Given this list of marker genes Or4c10b, Or6c3 (NCBI Gene Id 258544), Or5d3, Or52z1 (NCBI Gene Id 259121), Or2y8, Or7d10, Pip, Or4k38 (NCBI Gene Id 259136), Or2z2, Or8g23, Or2d2b, Or1j14, Calhm1, Or1e19, Or4a79, Or11g25, Or52m1, Or10ak16, Or13c7, Asic2, Or2b28, Or5bw2, Or3a4, Or2d2, Or10p1, Or6d14, Or52n2b, Or52z13, Or5p80, Or5w18, Or5p52, Or12d16-ps1, Or5p56, Or10g6, Or5b98, Or2b2b, Or6c70, Or4a2, Or6b2, Or9q1, Or7e168, Or2y14, Or5aq6, Or5b121, Or2ak7, Or51e1, Olfr363-ps, Or1e1, Or2g1, Or8b40, Or1e30, Or12e10, Or2w25, Or10ag52 (olfactory receptor family 10 subfamily AG member 52), Or5ak25, Or13e8, Or5b120, Or6c1b, Or5w20, Or1l4, Or6z6, Or6c66b, Or5p64, Tas2r108, Or4k40 (NCBI Gene Id 277562), Or5aq1b, Or8b12i, Or4b1, Or10al6, Or5p55, Or5e1, Or6d12, Or8b56, Or10q1b, Or2w1, Or5b24, Or2c1, Or9r7, Or8b49, Or52b3, Or8k27, Or1e26 (NCBI Gene Id 259025), Or2m12, Or10g9, Or2w1b, Or51ag1, Or2l13b, Or6c211, Tas1r2, Or10h1, Or8c20, Or4c1 (olfactory receptor family 4 subfamily C member 1), Or52n2c, Tas2r136, Or1e33, Or1j1, Or2n1, Or7e169, Or5d38, Or7a37, Or5ak24, Or2w6, Or10d5, Or5v1b, Or1f19, Or8g22, Or9a4, Or6c65, Or1ad6, Or6c219, Or1e1c, Or4a71, Or5c1, Tas2r144 (taste receptor, type 2, member 144), Or52ab2, Or10p22, Or5b122, Or2r3, Or7c19, Or8g2, Or2v2, Or2a12, Or12k5, Or6b2b (NCBI Gene Id 258228), Or4c111, Or2y1d, Or51l4, Rtp1, Or4k49, Or8b35, Or9k2, Or5ar1, Or6c210, Or7a42, Or11g7, Or51b4, Or7a40, Or10ag58 (olfactory receptor family 10 subfamily AG member 58), Or4a72, Or51f1, Or10ad1b (olfactory receptor family 10 subfamily AD member 1B), Or52d1, Or14c45, Or5au1, Tas2r140, Or2y3, Or52ad1, Or10x4, Or10ag54, Or10q3, Or5ac25, Or51ah3, Tas2r110, Or5p76, Slc6a3, P2rx3, Or2bd2, Or2aj6, Or5g23, Or5k15, Or4k5, Or8g2b, Or4c118, Or9a2, Or56b2j, Or10h28, Or52n4b, Or8j3c, Or8b1b, Or5g26, Or5d36, Or10al7, Or56b6, Or10u3, Or8b57, Or51b17, Or6k14 (NCBI Gene Id 259162), Or4e2, Or4c102, Tas2r131 (taste receptor, type 2, member 131), Or52ae9, Or2n1e, Or6c33, Or14a258, Or1j15, Or1af1, Or7g18, Or10d1b, Or5ac24, Or8d23, Or8b44 (NCBI Gene Id 258801), Or4c121, Or6c202, Gjb4, Or4a74, Or14c40, Or12k7, Or52n2, Or8b8, Obp1b, Or2d3c, Or5p79, Or5as1, Or6c205, Or8b50, Azgp1, Or2ad1, Or2w4, Or2ag2, Or4c11b, Or2t47, Rgs21, Or8b36, Or10v1, Or52d3, Or10g1, Or4x15, Or4c127, Or51b6, Or4c113, Or4k52, Or4c120, Or5ac22, Or4f14b, B3gnt2, Or2aj4 (olfactory receptor family 2 subfamily AJ member 4), Or5b95, Or10g3b, Or2at4, Or12e8, Or52a5b, Or51r1, Obp1a, Bpifb9a, Or10aa3, Or1o11, Or1o4, Or4x13, Or5k1b, Or8g24, Or5bb10, Or2a14, Or2y1e (NCBI Gene Id 258460), Trpv1, Or13a25, Or4n5, Or5p78, Or5m3, Or6f1, Or52e3, Or1n1, Or8k24, Or5w1, Or7g16, Or5m8, Or5p61, Or51i1, Or4c125, Or4c126, Or2b7, Or2h2, Or5al1, Or5m10b, Or1ab2, Or5w12, Or8k16, Or5b107, Or8b47, Or10aa1, Or10c1, Or8u3-ps, Or52s1b, Or9m1b, Or7g30, V1ra8, Or13f5, Or10x1, Or2t29, Or6aa1, Cfap69, Or12j3, Or6c217 (olfactory receptor family 6 subfamily C member 217), Or6c208, Or2h1, Asic1, Or5ac21 (NCBI Gene Id 258479), Or13a1, Or2w3b, Or2t48, Or5i1, Or2g25, Or51aa2, Or5b94, Or8k30, Or8b55, Vmn1r13, Or13c7b, Ric8b, Or2b4, Or51g1, Or5a1, Or4c29, Or5t9, Or9i1b, Or5h23, Or5d39, Nav2, Or5w11, Or5l13, Or4f17-ps1, Tas2r124, Bbs1, Or5g29, Cnga2, Or5g27, Or6c6c, Or8k53, Or9m2 (olfactory receptor family 9 subfamily M member 2), Or2y16, Or4z4, Or52j3, Or13p3, Or4b13, Or7c70, Or12j2, Or8g30, Tas2r115 (taste receptor, type 2, member 115), Or5ac19, Or8k25, Or4d11, Or10s1, Or2w3, Or5p72, Or4c109, Or4k36 (olfactory receptor family 4 subfamily K member 36), Scnn1b, Or5b111, Or52ae7, Or10d5j, Or52z14, Tas2r117, Or8b41, Or9g3, Or5k3, Or2ag2b, Or2ag16, Or52e4, Or2t45, Or5m13b, Or13c25, Or8d4 (NCBI Gene Id 258854), Or51a42, Or5p57, Or2a51, Reep2, Tas2r129, Or11g1, Or4m1, Or56a3, Gm7609, Or9s27, Or8k35, Or8k22, Pkd1l3 (NCBI Gene Id 244646), Car6, Or4c35, Mkks, Or5t18, Or8b1d, Or7g34, Or5w1b, Or4c12b, Or8g33, Or1aa2 (NCBI Gene Id 258289), Or10j2, Or2q1, Gnal, Or1a1, Or8b51, Or5m12, Or1o3, Or6c216, Or4p18, Or5ac17, Or4g7, Or5k1, Or2t46, Or1e35, Or1j8, Or5k16, Pde4a (NCBI Gene Id 52001), Or8k37, Or2o1, Or4c3, Or51h5, Or4k44, Or7e174, Tas2r105, Or10a49, Or8b54, Or2f1b, Or5o1, Or7g26 (olfactory receptor family 7 subfamily G member 26), Or14j6, Or1j13, Or5an1b, Or7g20 (NCBI Gene Id 257872), Or9q2, Or2a52, Tas2r104, Or2ag13, Or5ac23, Or5p5c-ps1, Or6c6b, Or1e32, Or5ac15, Or1e29 (olfactory receptor family 1 subfamily E member 29), Asic3, Or12d12, Or4p19, Or5t17, Or7e175, Or5t16, Or1l8, Or4x6, Gnb1, Or8g19, Or52a33, Or6z7, Or13g1, Or3a1b, Or8k33, Or6x1, Or52h1, Or4a27, Or4f53, Or51a39, Or52e5, Vmn1r48, Or8d6, Or11g24, Vmn2r26, Or13a22, Or52l1, Or2ag15, Or52w1, Or6c76, Cnga4, Or6c2, Or1e21, Or10g3, Or7g29, Or10ad1 (NCBI Gene Id 634104), Or6c200-ps1, Or10d4 (NCBI Gene Id 258087), Or9k2b, Or5b109, Or4k15, Or5w16, Or5b112, Or9g4, Or9g20, Or6c213, Cngb1, Or5v1, Or4p22, Or8b37, Or11j4, Or7a41, Or8k32, Or5an10, Or4d6, Or1j17, Or4l1, Or8c11, Or8k3, Or56b34, Or52n1, Or4d2 (NCBI Gene Id 258408), Or9g4b, Or5al6, Or11g27, Or10ag59, Or10am5, Or5ak22, Or6c69, Or2i1, Or5al7, Or13l2, Or52h2, Or5p58, Or5b101, Or8u10, Or14a257 (NCBI Gene Id 257905), Or52d13, Or10al3, B2m, Tas2r109, Or51m1, Tas2r114, Or5m9b, Or51q1, Or6z3, Or5b3, Or8c17, Or4s2b, Or8g28, Or52e7, Or8b43, Or5d35, Or52e18, Or5h25, Or5w22, Or8h6, Or5d40, Or10al4, Or10ac1 (olfactory receptor family 10 subfamily AC member 1), Or4c107, Or1j4, Vmn2r1, Or3a1d, Or10ah1-ps1, Or13a17, Or51ai2 (olfactory receptor family 51 subfamily AI member 2), Gm7582, Or52p1, Or7e178, Or4f14 (NCBI Gene Id 258023), Or5d37, Or14c43, Or10z1, Or8c16, Or52h9, Or5b124, Or8g35, Or10ag57, Or8d2, Or4c58, Or2l5 (olfactory receptor family 2 subfamily L member 5, NCBI Gene Id 258937), Or4a66, Or2y6, Taar7f, Or52ab7, Vmn1r49, Or5h26, Or4f15, Or6c75, Or8c13, Or6c74 (olfactory receptor family 6 subfamily C member 74), Or1e25, Or7d11, Or2b6, Or6n2, Or8g37, Or10d3, Or51f23, Nxnl2, Or5aq1, Or8g34, Or4c15b, Tas2r143, Or1ad1, Or9s18, Itpr3, Or52a20 (NCBI Gene Id 436002), Vmn1r44, Or5p62, Or14j8, Or10v9, Or2a7 (olfactory receptor family 2 subfamily A member 7), Or1ad8, Or52a24, Or2b11, Or7a36, Or10ak13, Or51e2, Or4c122, Or7e176, Or4q3, Or4a15, Or8h9, Gnat3, Or10n1, Or14c44, Or56b1, Or1m1, Or6c66, Or4d5, Tas1r1, Or4f59, Or1j20, Or2ah1, Or6c214, Or10g1b, Or8h7, Or4k41, Or5p6, Or51v14, Ubr3, Or5p63, Or52b1, Or52r1b, Or6c63-ps1, Tas2r139, Or7a35, Or10v5, Or5b123, Or8g21, Or51a5, Fzd2, Or8g26, Or4c52, Or52i2, Or4c123, Or8b39, Or10d4c, Or10j3, Or8u8, Or55b3, Or5p50, Or5b108, Or10b1, Or5ae2, Or6b6, Or4a67, Or7g27, Vmn1r47, Or4k77 (olfactory receptor family 4 subfamily K member 77), Or52z12, Or2y10, Or5d47, Tas2r125, Or51a25, Or2d3b, Or51d1, Or4a78, Rtp3, Or2ag17, Or10ab4, Or4f4b, Or10d1, Or10j3b, Or52b4, Or1j12, Or4f14d, Or7h8, Or12d15, Or52e2, Or9s15, Or2y13, Or9m1, Or56b1b, Ano9, Or2a5, Or1j19, Tas2r120, Or56b2, Or6c207, Or52s6, Or13p8, Or11i1, Or5p1, Or13p10, Or4c105, Or6c5, Or5h17, Or8j3, Or4c3d, Or51h1, Or6b1, Vmn1r239-ps, Or8b12b, Or4d2b, Or2h2c, Or8g27, Or2h15, Tas2r113, Or13a20, Or13p4, Or12d2, Or51i2, Or5m5, Or5b113, Or10al5, Or6b9, Or6z5, Or8c10, Or13a27, Or5ac16, Or2ab1, Drd2 (dopamine receptor D2), Or5p54, Or4k42, Or6n1, Or4f58, Or6c76b, Or6b13, Or5h27, Or12e13, Or4c112, Or10h5, Or4f61, Or52s19, Or5d43, Or2t43, Or8c18, Or8k1, Or2ag1b, Or6c69c, Or8c15, Or5b21, Or6s1, Or4p23, Or5b96, Or10ag53, Or4p7, Or7g32, Or1e22, Or8k17, Or2n1b, Vmn1r30, Or5p67, Or9e1, Or5w13, Or7g17, Or6c35, Or8u9, Or5d20-ps1, Vmn1r11, Or4a47, Gnat2, Tas2r107, Or1s2, Or6b3, Or4c31, Or52x1, Or1n1b, Or10q12, Or8g54, Or2k2, Or7a39, Or4c12, Or1j18, Or5an6, Or9s14, Or7g22, Or5b105, Or7e177, Or5al5, Or8d2b, Or2v1, Or56a5, Or51ac3, Vmn1r51, Or8b48, Olfr1060-ps1, Or9i16, Or55b10, Or9r3, Or10a5, Or5b118, Tas1r3, Or12k8, Or5d14, Or1o1, Or4b1c, Tas2r123, Tas2r116, Vmn1r40, Or7g28, Or52p2, Or9k7, Or4a75, Or2h1b, Or2ag12, Or56b35, Or7d9, Or1ak2, Or9i1, Plcb2, Or5d46, Or5b119, Or6c201, Or5w15, Or10a3, Or10ab5, Or4a39, Or5b97, Or8s10, Or6k2, Or10ak14, Or6d13, Or51l14, Or1j21, Or2a57, Or14a260, Tas2r137, Or4g17 (NCBI Gene Id 258379), Or8j3b, Or2av9, Or4f52, Or4n4b, Or9g8, Or13ae2, Tas2r118, Or5d16, Tas2r134, Or8g50, Or51a10, Or4k2, Or8b1c, Or4k48, Or2a56, Or6c38, Or2ag1, Or8b3b, Or4c110, Or52n4, Or4b1b, Or8k23, Or4k39, Or2ak5, Or5m3b, Or14j10, Or51aa5, Or10j7, Or4e1, Or2t1, Or51s1, Or10ak11, Adcy3, Or12e7, Or5w10, Tas2r121, Or12d13, Gnat1, Or8k39, Or10a3n, Or14j7, Or7g33, Or52ab4, Or13c7c, Or4d1, Or1i2, Or2t35, Or8k28, Or2f1, Or51q1c, Or2n1d, Or8c9, Or10a4, Vmn1r25, Or4c15, Or12d17, Or8s2, Or7g25, Or52e19b, Gng13, Or52k2, Or5ae1, Or5an1, Or8s16, Vmn1r53, Wnt10b, Or2ak4, Or4p8, Or52n5, Or6d15, Or10h1b, Or4a77, Or10a2, Or51ab3 (olfactory receptor family 51 subfamily AB member 3), Or9i14, Or4f47, Or6c88, Or2y1c, Or4c117, Or8b42, Or2t49, Or51f5, Or2y11, Or4k15b, Or10p21, Or5an1c, Cd36, Or5t15, Or3a10, Or4k1 (olfactory receptor family 4 subfamily K member 1), Or5l14, Or5p5, Or6z1, Or6c6, Or7r1, Or4c101, Tas2r119, Or1e23, Or11a4, Or8b101, Or5b12, Or5b106, Or10ag60, Or14j9, Or5g25, Or5m9, Or3a1, Or14j5, Or51a43, Or52u1, Or8k18, Or5j3, Olfr908, Or10al2, Or5a3, Or2aj5, Tas2r135, Dmxl2, Or2a20, Or2y15, Or5ak20, Scnn1g, Or5m13, Or14a259, Or4c11c, Or1x2, Or5b99, Or12e1, Or5g9, Or7a38, Or10ak7, Or4f6, Or11h23, Or5k17, Or4k37, Or5b102, Or5be3, Or8d1, Or13a18, Or5p70, Or5b12b, Or2d36, Or8b38, Vmn1r43, Or5w14, Or2y1, Or7g12, Or52m2 (NCBI Gene Id 257684), Or12d14-ps1, Trpa1, Or51f1e, Or2j3, Or8k41, Scnn1a, Or4c115, Or6k6, Or51a24, Or8b9, Or51k1, Or11q2, Or9s13, Or2ag19, Or8b12, Pkd2l1, Or2d4, Or2r2, Or7e170, Or5t5, Or8h8, Or10d4b, Or5aq7, Or2aa1, Or5p4, Or4k45, Or1j10, Or4e5, Or1r1, Or5m11b, Or10ak9, Or5ac20, Or2y1g, Or8g18, Or55b4, Or10q1, Or8a1, Or4p20, Or2y1f, Or52h7, Or10j27, Or4a81, Gucy2d, Or1e34, Or8k3b, Or7e166, Slc24a4, Or5h24, Or1e17, Or4d10c, Or4c10, Or2ag20, Or8h10, Tas2r138, Or7e173, Or6c68, Or11h6, Or8g53, Or9g10, Or6k8-ps1, Or5af1, Or1a1b, Or9s23, Or12e9, Or2z8, Or2ag18, Or8g17, Or4k6, Or5b116, Or5ak4, Or13a28, Or11n2, Or5m10, Rtp4, Or51b6b, Or8s5, Or9g19, Or4d10, Or52r1, Or6f2, Or52b2, Or11g2, Or5h22, Or2w2, Tas2r102, Or2j6, Or8g55, Or14a256, Or4a69, Lpo, Or4c11, Or12j5, Or5p51 (olfactory receptor family 5 subfamily P member 51), Or51af1, Or6y1 (NCBI Gene Id 631073), Vmn1r54, Or4c116, Omp, Or6c2b, Or7g19, Syt10, Ttc8, Or52n20, Or1q1 (NCBI Gene Id 258616), Or8g51, Vmn1r42, Or51v8, Or2p2, Or5ak23, Or4c114, Or7g31, Or13a21, Or1j16, Or4c106, Or51f23b, Or2y12, Rtp2, Or5d41, Or2b2, Or10j5, Vmn1r29, Ffar4 (NCBI Gene Id 209389), Or11h7, Or2a54, Or5p66, Tas2r103, Or11g26, Vmn1r46, Or13c3, Tas2r130, Or52e8b, Or4k47, Best2, Or4c124, Or5an9, Gfy, Or5p81, Or5p60 (olfactory receptor family 5 subfamily P member 60), Or8b1, Or4n4, Or5w19, Or52ac1, Bbs4, Or13p5, Or5p53, Or6c8b, Or51a6, Or4f7, P2rx2, Or4k51, Tas2r126, Or10ak12, Or6c206, Or8d1b, Or5h19, Or2t44, Or1j11, Or5t7, Or51f2, Tmc4, Vmn1r41, Lef1, Or10ad1c, Or8i2 (NCBI Gene Id 258763), Gnas, Or6c215, Or6c8, Vmn1r15, Or8b46, Or6k4, Or5d44, Or6c203, Or4k15c, Tas2r122 (NCBI Gene Id 630845), Or8b4, Or4f54, Or52a5, Or12j4 (NCBI Gene Id 258056), Or8k20 (olfactory receptor family 8 subfamily K member 20), Or10k2, Or4a70, Or8s8, Or6c1, Vmn1r45, Or52e8, Or51a8, Or4a76, Or10g7, Or4c104, Or4k35, Or2n1c, Or8b52, Or11h4, Or5af2, Or14j3, Or8b53 (olfactory receptor family 8 subfamily B member 53), Or1n2, Taar3, Or5d18, Or6p1, Or8w1 (NCBI Gene Id 258833), Vmn1r10, Or13n4, Or10ak8, Or1o2, Or6c212, Or8c8, Pigr, Or13d1, Tas2r106 (taste receptor, type 2, member 106), Or4f57, Or2a25, Or8b3, Or2at1, Or8g36, Or7g21, Or13a19, Or4f56, Or10a3b, Or8k38, Or8g4, Or51f1d, Or4l15, Or1p1, Or2z9, Or1f12, Or5d45, Or52n3, Or5bh3, Or2m13, Or51k2, Or5w8, Or10a3m, Or13a26, Or2r11, Vmn1r52, Or14j4, Or9i2, Or4a73, Or4g16, Or51g2, Or4a68, Or52s1, Or56a3b, Or4c100, Igf1, Or10u4, Or6e1, Vmn1r50, Or7g35, Or2t6, Or52e15, Or7e165, Or5p69, Or6c69b, Or5b117, Or3a1c, Or4b1d, Or56a4, Or13c7d (NCBI Gene Id 29849), Or5b104, Or11m3, Or14c39, Or1d2, Or2g7, Or5ap2, Calhm3, Or5p59, Or2l13, Pde1c, Or51t4, Or12e14, Or5k14, Or51a7, Or4x11, Or4d10b, Or14j2, Or2y17, Gm15433, Or1b1, Or10a48, Or6c5c, Vmn1r14, Or2f2 (olfactory receptor family 2 subfamily F member 2), Or4f62, Or8b12c, Or10ag2, Or14c46, Or2d3, Or5h18, Or8g32, Or5p73, Or6c3b, Ugt2a1 (UDP glucuronosyltransferase 2 family, polypeptide A1), Or2t26, Or8g20, Or5w17, Or52r1c, Or11l3, Or6c209, Or13a24, Taar4, Or1e16, Or6a2, Or8k40, Or1e1f, Or13j1, Or6ae1, Or2ak6, Or5p68, Or8g52, Or9a7, Or8a1b, Or10ag56, Or4c103, Or14j1, Or14c41, Or2y1b, Or4f60, Or5j1, Or5an11, Or4c108, Or10g9b, Or10d1c, Or11h4b, Taar5, Or4b12, Or10w1, here is a description of the gene set: Mouse Gene Set: GOBP_SENSORY_PERCEPTION_OF_CHEMICAL_STIMULUS species: Mus musculus The series of events required for an organism to receive a sensory chemical stimulus, convert it to a molecular signal, and recognize and characterize the signal. This is a neurological process.